The following is a description of a gene set: studied in species Homo sapiens Genes predicted to be targets of miRBase v22 microRNA hsa-miR-331-5p in miRDB v6.0 with MirTarget v4 prediction scores > 80 (high confidence targets). from publication Chen Y, Wang X (PMID 31504780) Human Gene Set: MIR331_5P, and this is the list of marker genes: RAP2C, HAUS2 (NCBI Gene Id 55142), FHIP1A, ALAD (aminolevulinate dehydratase), PPFIA1, LHFPL5, ZDHHC2, SLC9A6, C1RL, TRAPPC8, KLRG1, UTP14C, PPP1R3B, MAP3K21, ASGR1, KPNA3, IGF2BP3, ZMYM5, CPED1, RELN, MFSD1 (NCBI Gene Id 64747), AQP4, TSPAN6, TRIB1, C5orf63, BRMS1L, TNRC6C, HOXC8, PDGFD, RNASEH2B, SPCS2, DDTL, POLR2K, CRBN, AFF4, TYW5, RANBP3L, CDH5, TKTL2 (transketolase like 2), MRPS33, SNTN, PDE1A, FUT9, CIART, RNF217, DAB2, HDX, METTL14, CREM, ZNF655, TMEM170B, SOX18, PFKP, CCL21, ZFHX3, CCSAP, SGPP1, DHX35, TDG, ZNF391, CCDC73, UBL3, ARHGAP44, AIMP1, MAP10, INA, RFX3, CKAP2L, FNDC3B, DOCK5, NAIP, TRAT1, NAALADL2, MAP3K20, AVIL, DMAC1, RAI2, SMIM8